The following is a description of a gene set: Down-regulated genes from the set E (Fig. 5a): specific signature shared by cells expressing either MLL-AF4 or AF4-MLL fusion proteins alone, and those expressing both fusion proteins. Human Gene Set: GAUSSMANN_MLL_AF4_FUSION_TARGETS_E_DN The reciprocal chromosomal translocation t(4;11) is correlated with infant, childhood, adult and therapy-related high-risk acute leukemia. Here, we investigated the biological effects of MLL.AF4, AF4.MLL or the combination of both reciprocal fusion proteins in a conditional in vitro cell culture model system. Several parameters like cell growth, cell cycling capacity, apoptotic behavior and growth transformation were investigated under physiological and stress conditions. Co-transfected cells displayed the highest resistance against apoptotic triggers, cell cycling capacity and loss-of-contact inhibition. These analyses were complemented by gene expression profiling experiments and specific gene signatures were established for each of the three cell lines. Interestingly, co-transfected cells strongly upregulate the homeobox gene Nanog. In combination with Oct4, the Nanog homeoprotein is steering maintenance of pluripotency and self-renewal in embryonic stem cells. Transcription of Nanog and other stem cell factors, like Oct4 and Bmi1, was verified in biopsy material of t(4;11) patient cells which express both reciprocal t(4;11) fusion genes. In conclusion, the presence of both reciprocal MLL fusion proteins confers biological properties known from t(4;11) leukemia, suggesting that each of the two fusion proteins contribute specific properties and, in combination, also synergistic effects to the leukemic phenotype. from publication Gaussmann A, Wenger T, Eberle I, Bursen A, Bracharz S, Herr I, Dingermann T, Marschalek R (PMID 17130830) studied in species Mus musculus, and this is the list of marker genes: MORC4, ITM2A, GPNMB, RAB3B, NEO1, GPT2, TRIB3, TAF7L, STBD1, ARMCX4, SERPINB9, MGST1, PEG3, IGFBP4, PLAGL1, VLDLR, TUBB3, CDSN, DACH2, SGK3, COL6A3, ANGPTL6